The following is a description of a gene set: The process in which the sperm binds to the zona pellucida glycoprotein layer of the egg. The process begins with the attachment of the sperm plasma membrane to the zona pellucida and includes attachment of the acrosome inner membrane to the zona pellucida after the acrosomal reaction takes place. Mouse Gene Set: GOBP_BINDING_OF_SPERM_TO_ZONA_PELLUCIDA studied in species Mus musculus, and this is the list of marker genes: Pmis2, Pcsk4, H1f6, Cct7, Cct5, Arsa, Adam32, Adam18, Cct8, Zp3, Cct2, Lypd4, Zan, Tex101, Zpbp (NCBI Gene Id 74977), Acr, Cct6a, Ubap2l, Glipr1l1, Cct3, Hspa1b, Clgn, Adam1b, Zp3r, Tcp1, Zp1, Adam3, Fetub, Vdac2 (NCBI Gene Id 22334), Astl, Zp2, Prss55, Tnp2, Tmprss12, Prss37, Zpbp2, Adam5, Spaca4, Aldoa, Crisp4, Adam2, Ovgp1, Atp8b3, Hspa1l, Spa17, Ly6k, Smcp, Slxl1, Garin3, Cct4, Adam1a, B4galt1